The following is a description of a gene set: Human Gene Set: MIR920 studied in species Homo sapiens Genes predicted to be targets of miRBase v22 microRNA hsa-miR-920 in miRDB v6.0 with MirTarget v4 prediction scores > 80 (high confidence targets). from publication Chen Y, Wang X (PMID 31504780), and this is the list of marker genes: RAB9B, IPO13 (NCBI Gene Id 9670), VPS36, RGR, DUSP23, ATP8A1 (NCBI Gene Id 10396), PPFIA4 (NCBI Gene Id 8497), ABI2, TNRC6B, MICAL3, DSE, NPTX1, OR7D2, THRB (thyroid hormone receptor beta), STK36, CDK19, CLEC4E, NOA1, NUCB2, ATP8A2, OR11A1, GINS2, PLXNA4, ZNF510, LAMTOR3, ST8SIA1, AK9, PTAR1, MYCT1, SHPRH, CUEDC1, EDA2R (ectodysplasin A2 receptor), HIC1, PML, ATPAF1, COL9A2, FBXO10, LY6G6C, SMCR8, PPP1R18, RBPMS2, SPRYD4, KAT6A, CCDC157, MBNL3, MYORG, PRX, ATP11A, LMX1A, FLRT1, RASGRP3, NETO2